Given this list of marker genes Amot, Zfp729a, Qpct, Zfp629 (NCBI Gene Id 320683), Hcfc1, Hecw2, Stat4, Klhl29, Zfp735, Pramel3b, Bcl2l14, Brpf1, Gje1, Arhgef9, Nab1, Lrtm1, Tcf24, Nr3c1, Tmed7, Map2, Trdmt1, Ppfia1, Pramel3c, Gcnt4, Pspc1, here is a description of the gene set: from publication Chen Y, Wang X (PMID 31504780) Genes predicted to be targets of miRBase v22 microRNA mmu_miR_8098 in miRDB v6.0 with MirTarget v4 prediction scores > 80 (high confidence targets). studied in species Mus musculus Mouse Gene Set: MIR_8098